Given this list of marker genes SOAT1, ACBD6, GCDH, ACADVL (NCBI Gene Id 37), SCP2, DBI, ECI2, PNPLA3, ACBD3 (NCBI Gene Id 64746), ACBD5, ACOT7, OXER1, SOAT2, ACBD4, ACBD7, here is a description of the gene set: studied in species Homo sapiens Binding to fatty acid derivative. Human Gene Set: GOMF_FATTY_ACID_DERIVATIVE_BINDING